Given this list of marker genes ESYT1, PTPN6, NOXO1, ISG15, CST3, OSBPL8, PSMB9, ANGPTL4, PSME2, CASP4, LRRK1, LAP3, IFNG, JAML (NCBI Gene Id 261728), COG4, CTSH, CCL8, MLKL, NBEAL2, CD8A, SLAMF7, FMNL1, SLCO2A1, SDHAF2, CASP1, CCL5, TSPO, SBNO2, GALNT3, ICOS, DOP1B, MTMR1, ID2 (NCBI Gene Id 3398), GVINP1 (GTPase, very large interferon inducible pseudogene 1), CHSY1, GRAP2, PLA2G4A, RGS16, USP18, USB1, IL2RA, CD69, TNFRSF14, ANK2, PRKCH, KLRD1, RGS1, STXBP1, MOCOS, NOTCH1, RABIF, FLI1, MGST1, SOCS1, DPYD, ENTPD1, IL18RAP, RINL, USP4, TRAFD1, CACNB4 (calcium voltage-gated channel auxiliary subunit beta 4), ELMO1, SLAMF1, GZMA, PSD4, CLEC2D, CH25H, KLRG1, INSRR, GIMAP4, SH2D2A, GZMB, THEMIS, IFNGR1, ESR1, PSMB10, FURIN, XAF1, SERPINB9, SCFD1, CBLB, AHNAK, VWA5A, IL2RB (interleukin 2 receptor subunit beta), TBL1XR1, SLC4A4, ASB13, CD3G, ABHD16A, CPT1A, PSMB8, CMTM6, PDGFD, RNF115, CYBA, IFIT2, PARP3, GMFG, RNF114, AMPD3, TRIM5, ANXA4, VPS11, EPSTI1, CD3E, SH3BP2, IL15RA, PARP11, RNF19B, IRF1, KLRC1, CTSW, UBL7, FGL2, NAMPT, SP110, OAS3, GIMAP6, CST7, GBP5, IL13RA1, CIITA, IL18R1, GNB4, TEX14 (NCBI Gene Id 56155), PTPN22, CASP7, H2BC4, ICAM1, NFKBIA, TNFSF10, DAXX, SLC35F5, SLC7A3, TPCN2, KLHL6, RAB11A, EIF4E3, PPP6R1 (protein phosphatase 6 regulatory subunit 1), TAFAZZIN, IL12RB2, MYO1G (NCBI Gene Id 64005), CENPJ, STOM, CORO2A, NOD1, CYSLTR2, PRPH, UNC93B1, GSAP, MIR99A, ELMO2, CLIC4, CD3D, ITGAL, TRPV2, IRAK2, CCRL2, TRIM21, IDO1, MALT1, IKZF1, JAK1, P2RX3, PRF1, IFITM1, MCTP2, LMO4, ADGRG5, GSDMD, MCL1, BATF2, LY6S, P2RY10, FAM53A, here is a description of the gene set: The ability of dendritic cells (DCs) to activate immunity is linked to their maturation status. In prior studies we have shown that selective antibody-mediated blockade of inhibitory FcgRIIB receptor on human DCs in the presence of activating immunoglobulin (Ig) ligands leads to DC maturation and enhanced immunity to antibody-coated tumor cells. Here we show that Fcg receptor (FcgR) mediated activation of human monocytes and monocyte-derived DCs is associated with a distinct gene expression pattern, including several inflammation associated chemokines as well as type 1 interferon (IFN) response genes including the activation of signal transducer and activator of transcription 1 (STAT1). species: Homo sapiens from publication Dhodapkar KM, Banerjee D, Connolly J, Kukreja A, Matayeva E, Veri MC, Ravetch JV, Steinman RM, Dhodapkar MV (PMID 17502666) Genes down-regulated in dendritic cells: untreated versus anti-FcgRIIB. Human Gene Set: GSE7509_UNSTIM_VS_FCGRIIB_STIM_DC_DN